The following is a description of a gene set: Multiple myeloma is an incurable plasma cell malignancy for which existing animal models are limited. We have previously shown that the targeted expression of the transgenes c-Myc and Bcl-X(L) in murine plasma cells produces malignancy that displays features of human myeloma, such as localization of tumor cells to the bone marrow and lytic bone lesions. We have isolated and characterized in vitro cultures and adoptive transfers of tumors from Bcl-xl/Myc transgenic mice. Tumors have a plasmablastic morphology and variable expression of CD138, CD45, CD38, and CD19. Spectral karyotyping analysis of metaphase chromosomes from primary tumor cell cultures shows that the Bcl-xl/Myc tumors contain a variety of chromosomal abnormalities, including trisomies, translocations, and deletions. The most frequently aberrant chromosomes are 12 and 16. Three sites for recurring translocations were also identified on chromosomes 4D, 12F, and 16C. Gene expression profiling was used to identify differences in gene expression between tumor cells and normal plasma cells (NPC) and to cluster the tumors into two groups (tumor groups C and D), with distinct gene expression profiles. Four hundred and ninety-five genes were significantly different between both tumor groups and NPCs, whereas genes were uniquely different from NPCs in tumor group C and genes were uniquely different from NPCs in tumor group D. Similar to human myeloma, the cyclin D genes are differentially dysregulated in the mouse tumor groups. These data suggest the Bcl-xl/Myc tumors are similar to a subset of plasmablastic human myelomas and provide insight into the specific genes and pathways underlying the human disease. Human Gene Set: BOYLAN_MULTIPLE_MYELOMA_PCA3_DN from publication Boylan KL, Gosse MA, Staggs SE, Janz S, Grindle S, Kansas GS, Van Ness BG (PMID 17483317) studied in species Mus musculus Top down-regulated genes from principal component 3 (PCA3) which captures variation among different plasma cell tumors arising from overexpression of BCL2L1 and MYC., and this is the list of marker genes: TSPAN2, LIFR, BST1, CEACAM1, ANXA4, RSPH9, RAG1, RIN3, IGKV2D-29, CAPSL, ADAM19, PHKA1, MYL9, GAS7, DENND4C, ECI2 (NCBI Gene Id 134779), PTGR1, CYTH4, CASP7, APOBEC2, CCND3, TMEM141, TOP2B, FLOT2, IL7R, SLC15A2, CASP1, CSTF2T, EHHADH, IGLC6, GSN, RSPH1, IPCEF1, ARHGAP21, CYSLTR1, WFDC21P, STOM, ZNF878, PRM1, RELN, SKP2, HSD17B13, STK3, CTNNA1, TIFAB, ST3GAL5, PCBP4, DDX3Y, ABHD8, IGLV7-43 (immunoglobulin lambda variable 7-43), SUCLG2, TNNI2, DNM1L, HOXC4, KNDC1, ZCCHC14, ASB2, CRYBG1, B3GNT8, ZBED4, GSDMD, NXPE2, RDX (radixin), ATP11A, EIF2S3, MARCKS, UPB1, SH3BP1, GGTA1, APC, HEATR5B, LXN